The following is a description of a gene set: A simultaneous engagement of different pathogen recognition receptors provides a tailor made adaptive immunity for an efficient defence against distinct pathogens. For example, cross talk of TLR and c-type lectin signalling effectively shapes distinct gene expression patterns by integrating the signals at the level of NF-κB. Here, we extend this principle to a strong synergism between the Dectin-1 agonist, curdlan, and an inflammatory growth factor, GM-CSF. Both together act in synergy in inducing a strong inflammatory signature which converts immature DCs to potent effector DCs. A variety of cytokines (IL-1β, IL-6, TNF-α, IL-2 and IL-12p70), costimulatory molecules (CD80, CD86, CD40 and CD70), chemokines (CxCl1, CxCl2, CxCl3, CCl12, CCl17) as well as receptors and molecules involved in fugal recognition and immunity such as Mincle, Dectin-1, Dectin-2 and Pentraxin 3 are strongly up-regulated in DC treated simultaneously with curdlan and GM-CSF. The synergistic effect of both stimuli resulted in strong IKBα phosphorylation, in its rapid degradation and in enhanced nuclear translocation of all NF-κB subunits. We further identified MAPK ERK, as one possible integration site of both signals, since its phosphorylation was clearly augmented when curdlan was co-applied with GM-CSF. Our data demonstrate that the immunomodulatory activity of curdlan requires an additional signal provided by GM-CSF to successfully initiate a robust β-glucan specific cytokine and chemokine response. The integration of both signals clearly prime and tailor a more effective innate and adaptive response against invading microbes and fungi. Genes down-regulated in bone marrow-derived dendritic cells treated with 1,3-beta-D-oligoglucan: low dose versus high dose. from publication Min L, Isa SA, Fam WN, Sze SK, Beretta O, Mortellaro A, Ruedl C (PMID 22250091) Human Gene Set: GSE32986_CURDLAN_LOWDOSE_VS_CURDLAN_HIGHDOSE_STIM_DC_DN species: Homo sapiens, and this is the list of marker genes: TRAF3, TMEM178A, RAB20, SEC23IP, TNFSF9, NCOA7, NR1H3, SYK, FZR1, ARIH1, PTX3, CCL2, LMO4, HLA-DRB1, GRHL1, IFIT2, PSTPIP2, FNBP1L, TMEM26, CHAMP1, CD80, MMP14, F3, UAP1, POGK, PHLDA1, SIN3B (SIN3 transcription regulator family member B), FABP3 (fatty acid binding protein 3), FGR, ETV3 (ETS variant transcription factor 3), NAPSA, UBE4A, SLC16A10, GRWD1, FAM20C, TOR3A, GSPT1, PTPRE, ADAP1, PSME2, GPR17, SQSTM1, FAS, EDNRB (NCBI Gene Id 3282), TGM2 (transglutaminase 2), SLC31A2, ZNF654, CRTC2, SLAMF8, ZMIZ2, TSR1, CASP4, FAM241A, PLK3, ATXN7L1, JARID2, NECTIN2, EBI3, MREG, GPR85, HERPUD1, MIF4GD, CX3CL1, RSAD2, SDE2, IFIT3, DOT1L, ITPRID2, IKBKE, PLAGL2 (NCBI Gene Id 5326), MET, CSF2, GADD45B, IFRD1, TNFRSF1B, PELI1, NOP2, LTB, SLC13A5, EXT1, ISG20, HVCN1, SF1, CDYL2, IRAK2, NCF4, SRGN, EXOC3L4, RAB10, RELA, CFLAR (CASP8 and FADD like apoptosis regulator), NIPAL1, IFIT1B, BCL2A1, NLRC5, PDGFA, SOCS2, IL6ST, MDM2, RCL1, RAB12, GPBP1, PPP1R12B, MRPS18B, HCK, U2AF1, LRP8, SUB1, STIM2, PROCR, SLC2A6, GAS7, PTPN2, PNRC1, PIR (NCBI Gene Id 8544), DONSON, SLC7A11, GSAP, LYST, GCA, SDC1, RABGEF1, CCL4, SUSD6, TRPS1, ALAS1, REST, TOP1, WDR74, GPD2, PLXNA2, DNAJA2 (DnaJ heat shock protein family (Hsp40) member A2), PTPRJ, CYRIA, RHBDF2, STBD1, ZNF516, VASN, NIBAN3, SPI1, AGRN, PGLYRP2, SRP54, ID2, GRAMD1B, SMPDL3B, SDC4, FLRT3, LAD1, TNFAIP2, CLEC5A, RBPMS2, JAK2, KLF10, HSPA1A, FOXP4, EML4 (EMAP like 4), NCOA5, CXCL16, RHOF (NCBI Gene Id 54509), ZNRF1, LCP2, ABHD6 (NCBI Gene Id 96026), CIITA (NCBI Gene Id 4261), HIVEP1, CHD2, PEX16, DAPP1, UBE2F, IL1RN, PRDM1, SLC2A1, SERTAD2, SRXN1, PLAUR (NCBI Gene Id 5329), PPP1R15A, EIF6, SEPTIN11, RAVER1, IRF1, SCN1B, LYNX1, TRAF1 (NCBI Gene Id 7185), SERPINB2, IL36G, ADAM23, SPRYD7, FPR2, NINJ1, SOWAHC, RASA2, C3, ABCC1, ZSWIM4, THEM6, RAPGEF2, IL12B, SNX20, PLPP3, TMEM120B